Given this list of marker genes KIT, LCK, GRB2, SOCS6, SH2B2, KITLG, LYN (LYN proto-oncogene, Src family tyrosine kinase), YES1, PRKCA, SH2B3, SOCS1, FYN, SRC, CBL, SOS1, PTPN6, here is a description of the gene set: Reactome Pathway: Regulation of KIT signaling part of: Signaling by SCF-KIT species: Homo sapiens SCF induced proliferation is negatively regulated by various proteins including SHP1, PKC, CBL, SOCS1, SOCS6 and LNK.